The following is a description of a gene set: Human Gene Set: MIR503_5P studied in species Homo sapiens Genes predicted to be targets of miRBase v22 microRNA hsa-miR-503-5p in miRDB v6.0 with MirTarget v4 prediction scores > 80 (high confidence targets). from publication Chen Y, Wang X (PMID 31504780), and this is the list of marker genes: ZNF367, SALL3, MAP2K1, EPHB2, PISD, CCND2, CCND1, ARMH4 (NCBI Gene Id 145407), TSC22D2, RFX3, ABCF3, N4BP1, KLHL26 (kelch like family member 26), SPRED1, FGF7, KANK1, ZFHX4, KCNJ2 (NCBI Gene Id 3759), DNAJA2, STOX2, IPO7 (NCBI Gene Id 10527), ZER1, ANKS1A (ankyrin repeat and sterile alpha motif domain containing 1A), CMPK1, SMURF1, ARL2, RTN4, FAM135A, LRRC58, NDUFA4, PAPPA, RASGEF1B, DCLK1, ASH1L, KIF1C, SYDE2 (NCBI Gene Id 84144), CDKN2AIP, LURAP1L, RIF1, YTHDC1, FGF2, UNC80, MEX3C, SMURF2, CCNE1, OMG, PLAG1, MGAT4A, BTRC, KIF5C, CDCA4, SMAD7, RNF144B, PTPN3, ZNRF3, ZNRF2 (NCBI Gene Id 223082), TMEM245, PTPN4, ZNF423 (zinc finger protein 423), CPEB2, KLHL2, SLC20A2, CYP26B1, SALL1, WIPI2, SOCS6, KDSR, WEE1, KIF21A, BMPR1A, ZBTB39, G2E3 (G2/M-phase specific E3 ubiquitin protein ligase), VEGFA, USP2, CDK8, PABIR1, FBXW7, RICTOR, TMCC1, RNF41, AKT3, MYB, KIF23, CREBL2, EMC6, UBE4B, CPEB3, DENND1B, SLC11A2, TMEM100, SRPRA (NCBI Gene Id 94501), ANLN, USP25, ZNF622, SEC24A, KPNA3, MOV10, RECK, HECTD1